The following is a description of a gene set: A heterodimeric nucleotide-excision repair complex that has endonuclease activity specific for bubble structures characteristic of certain DNA lesions. The subunits are known as XPF/ERCC4 and ERCC1 in mammals, and Rad1p and Rad10p in S. cerevisiae. Mouse Gene Set: GOCC_ERCC4_ERCC1_COMPLEX studied in species Mus musculus, and this is the list of marker genes: Xrcc4, Ercc4 (excision repair cross-complementing rodent repair deficiency, complementation group 4), Ercc1, Slx4, Xrcc1